Given this list of marker genes Pld6, Tdrd7, Etv6, Sos1, Tdrd5, Tdrd6, Tfcp2l1, Kif5b, Synj2bp, Tdrd1, Tdrkh, Padi6, Naglu, Rrn3, Zmiz1, Fosl1, here is a description of the gene set: Mouse Gene Set: GOBP_CYTOPLASM_ORGANIZATION studied in species Mus musculus A process that is carried out at the cellular level which results in the assembly, arrangement of constituent parts, or disassembly of the cytoplasm. The cytoplasm is all of the contents of a cell excluding the plasma membrane and nucleus, but including other subcellular structures.